The following is a description of a gene set: studied in species Homo sapiens The formation of mesodermal clusters that are arranged segmentally along the anterior posterior axis of an embryo. Human Gene Set: GOBP_SOMITOGENESIS, and this is the list of marker genes: MYF5, XRCC2, DKK1, SMAD4, DMRT2, NKX3-1, PRKDC, CDX2, POGLUT1, MESP1, PPP2R3A, TAF10, TMED2, ZEB2, TBXT, EPB41L5, MESP2, TCAP, PSEN1, RIPPLY1, MYF6, LFNG, MIB1, TBX6, ABI1, FOXC2, NRARP, LEF1, POFUT1, TCF15, FOXF1, EP300, WNT5A, FOXC1, MEOX2, BMPR1A, MEOX1, TBX18, ATM, GDF3, SFRP1, DLL3, NCKAP1, FOXB1, CRB2 (NCBI Gene Id 286204), RBPJ, KAT2A, TP53, NKD1, NOTCH1, MSGN1, PLXNA2, CDX1, SEMA3C, HES7 (NCBI Gene Id 84667), DLL1, MED12, SMAD3, NLE1, PALB2, LHX1, WNT3A, COBL, SFRP2, AXIN2, RIPPLY2, PCDH8